The following is a description of a gene set: species: Homo sapiens Genes having at least one occurrence of the motif KRCAGGAARTRNKT in the regions spanning 4 kb centered on their transcription starting sites. This matches the ETS2 transcription factor binding site V$ETS2_B (v7.4 TRANSFAC). Human Gene Set: ETS2_B, and this is the list of marker genes: SPNS3, STARD13, LRP5, PCDH1, STX19, RBMS2, S100A10, LINC03040, LGALS4, DOCK11, PGF, IL7R, FGFR4, PSEN1, PUS7L, C1QTNF5, GNG11, LYN, WDFY4, RGS3, FOXO3, MIR22HG, FAM110A, HOXA10, APOBR, CDKN1B, E2F3, C1QTNF6, WNT9A, CAMK2A (NCBI Gene Id 815), LYL1, ZNF532, ANGPT1, LINC01565, PTTG2, PPP1R9B, USP3, DIXDC1, ORC4, PAX6, BCL2L2, ITGB7, EPHA2, RAC1, GTF2B (general transcription factor IIB), CPNE8, CITED2, MYH10, ZBTB7B, FLNC, IRAK4, OLFM1, NT5C3A, FURIN, CKB, CACNA1D, MAPKAPK2, MIR137HG, PAK3, SBF2, C22orf15, ZBTB7A, STRBP, TMEM131L, PSIP1, CTSW, REST, TYRO3, FUT10, ZNF800, TMEM164, TREML1, SCN2A, FAM20A, RWDD4 (NCBI Gene Id 201965), ACTR2, CAST, FOXJ3, GCNT2, WDR81, MAP4K1 (NCBI Gene Id 11184), TMEM100, POU2AF1, SLC31A1, LAT, RASA3, IL13, DLGAP4, S100A9, CALM2, GMPR2, TCERG1, RNF43, NEDD8, ANGPTL1, TMEM71, IKBKB, CORO1C, KLF9, PTGIR, CREB3, MIDEAS, NR1D1, ARHGEF12, ADAMTS3, TMEM154, PPP1R12A, AP2B1, ARAP3, VASP, TREX2, CCDC85B, RNF128, KCNQ1DN, ARHGEF15, ATOH8, RUNDC3A, RAB43, EVX1, SF1, ACTR3, PTGDR2, ESAM, NIPBL, DAB2IP, AAMP, ESM1, MCTS1, IL12B, CRK, DLC1, ZNF35, BCL3, L3MBTL2 (L3MBTL histone methyl-lysine binding protein 2), DOCK4, ZNF205, LIFR, MUC13, LIMD2, HOXC4, ZEB2, MAP3K11, VDAC2, ARHGDIB, CRTC2, CHMP1B, PCDH7, ATP5PD, ZHX2 (NCBI Gene Id 22882), RAB20, CTHRC1, DOK1, FLI1, EGFLAM, TMEM204, AGBL5, PITPNB, MEIS2, RNF40, FYN, ZNF276, ARAP1, CANX, VIP, RAB11A, NUFIP2, TNNI2, LANCL3, VCL (vinculin), CDH5, TRAPPC11, SPI1, GPR162, GALE (NCBI Gene Id 2582), DMTF1, TWIST1, CD248, TIMP4, MAP9, SSBP4, DPP3, APBA1, CEBPG, CAMK1D, NHERF1, TMOD3, STAP1, TEAD3, SESTD1, RLIM, TSC22D3, CDK12, EIF3K, CTCF, GSDMA, MYCT1, ZMAT3, CCDC91, CUEDC1, IL11RA, SHC3, EIF5A (NCBI Gene Id 1984), PPRC1, NRP1, SPARC, CCDC88B, LDB2, TUSC3, IMPDH1, ZNF143, EGR1, KDM6A, TREML2, LST1, TLN1, NPAS2, BAZ2A, CNKSR1, BTBD16, B4GALNT1, ITPR2, ZNFX1, CLEC14A, BZW2, SPATA6, SLC43A2 (NCBI Gene Id 124935), GIT2, PLA2G4F, DGKZ, IER5L (NCBI Gene Id 445576), IRAG2, RASAL1, HOXA1, RHOV, SLC39A11, SIPA1, CLTA, ARHGAP4, VWA5A, HAPLN1, KLF12, STX5, TCF12, LOXL3, RAP1GAP, EFNB3, DPPA4, KDF1, IGF1, TRMT2B (tRNA methyltransferase 2 homolog B), MMP3, LCP1, HCAR1, SAFB, GNB1L, TBC1D10C, ADNP, TYROBP, SP3, ACY3, KALRN, SEMA4C, ARHGAP30 (NCBI Gene Id 257106), RGS12, PNKD, NHSL2, TSPAN1, TRPC4AP, GPR107, TGIF2, ELMO1, RTKN, CLSPN, KCNMB3, PLEKHH2, CA4, ARHGEF6, ATP8B2, FGR, TAF5 (NCBI Gene Id 6877), NIPAL2, RTL10